Given this list of marker genes CCDC88C, MID1IP1, TTBK2, SLAIN1, PDE4DIP, CDH5, SNCA (NCBI Gene Id 6622), CAMSAP2, MAP1A, RPS3, TAOK1, GIT1, FGF13, APC, NUMA1, CKAP2, TUBB4A, BBOF1, MAP1S, CLIP1, ATXN7, SKA1, ARL2, SPAST, AKAP9 (A-kinase anchoring protein 9), INPP5J, CKAP5, AURKB, CDK5RAP2, STMND1, HAUS6, STMN3, SPEF1, PAK1, DYRK1A (dual specificity tyrosine phosphorylation regulated kinase 1A), HAUS8, GAS2L2, HDGFL3, DRG1 (NCBI Gene Id 4733), MAPRE1, TRPV4, BMERB1, PSRC1, MAPRE3, HSPA1A, STMN1, SKA2, MET, OCLN, STMN2, PPP2CB, HAUS5, CAV3, HAUS1, HDAC6, DIAPH3, DCTN1, KATNB1, CDK5R1 (NCBI Gene Id 8851), HAUS3, FKBP4, RAC1, TBCD, CDKN1B, STMN4, CLASP1, TOGARAM1, MAP2, PRUNE1, GBA2, NME7, MECP2, CLASP2, ARHGEF2, TRIM54, MAPRE2, MAPT, KIF21A, SLAIN2, HAUS7, HAUS4, CAMSAP3, FES, TPX2, WDR47, SLC39A12, HAUS2, CAMSAP1, NAV3, PPP2CA, CIB1, ARHGEF7, HSPA1B, EML2, APC2, GAS2L1, ANKRD53, MAP1B, SPECC1L, ABL1, MAP6D1, CLIP3, SKA3, MID1, here is a description of the gene set: Any process that modulates the frequency, rate or extent of microtubule polymerization or depolymerization by the addition or removal of tubulin heterodimers from a microtubule. Human Gene Set: GOBP_REGULATION_OF_MICROTUBULE_POLYMERIZATION_OR_DEPOLYMERIZATION studied in species Homo sapiens